Given this list of marker genes Esrrb, Pak1, Aldh1a3, Nr5a2, Nr3c1, Snai2, Trim68, Vps18, Shq1, Dnaja1, Pagr1a, Nkx3-1, Ncor2, Trerf1, Ppargc1b, Cst11, Nr2c1, Lhcgr, Ren1, Appl2, Med1, Zfp536, Ucn3, Heyl, Cyp26a1, Kdm4c, Kank2, Pou4f2, Rnf6, Asxl1, Sfrp1, Nr1d1, Safb2 (scaffold attachment factor B2), Nr1h3, Crkl, Calcoco1, Sst, Ptges3, Safb, Dhrs3, Ghr, Kmt2d, Ddx5, Rwdd1, Lmo3, Snw1, Ddx17, Vps11, Brca1, Foxa1, Rela, Nedd4, Rbfox2, Cnot1, Cnot2, Phb2, Ar, Dab2, Esr1, Nr0b1, Ywhah, Sp1, Rhoa, Actn4, Adipor2, Park7, Per1, Ppard (NCBI Gene Id 69050), Wbp2, Rarg, Ep300, Ncoa1, Greb1l, Fkbp4, Kdm5d, Ncoa2, Ptpn11, Scgb2a2, Clock, Lats2, Foxp1, Cnot3, Pparg, Trp63, a, Trip4, Cry2, Lancl2, Gh, Pml, Akr1c18, Klf2, Nr5a1, Rxrb, Nr3c2, Trim24, Or51e2, Ghsr, Pgr, Nr1h2, Acsl1, Padi2, Abhd2, Ppara (peroxisome proliferator activated receptor alpha), Cnot9, Calr, Crh, Ufsp2, Hdac1, Cry1, Ppp5c, Foxh1, Hmga2, Zbtb7a (zinc finger and BTB domain containing 7a), Rara, Esrrg, Cyp26b1, Mapk1, Sstr1, Prcp, Nr1d2, Crhbp, Carm1, Ncor1, Lbh, Aldh1a2, Adipor1, Tgif1, Sstr3, Tmf1, Pim1, Bdnf, Sstr5, Ddrgk1, Lats1, Pten, Esr2, Trh, Zmiz1 (zinc finger, MIZ-type containing 1), Rxfp1, Gper1, Skp2 (S-phase kinase-associated protein 2, NCBI Gene Id 75034), Gprin3, Ntrk2, Adipoq, Ptf1a, Csnk2b, Klf9, Dnaaf4, Slc27a1 (solute carrier family 27 (fatty acid transporter), member 1), Rxra, Pde3a, Ctbp2, Ubr5, Agrp, Rxfp2, Zdhhc7, Nodal, Ucn2, Uba5, Mn1, Kdm3a, Taf7, Mettl21c, Strn3, Thrb, Prlr, Fshr, Phb1, Rarb, Sstr4, Parp1, Gcgr, Src, Tshr, Ufl1, Appl1, Sstr2, Rxrg, Pias2, Crebrf, Errfi1, Kmt2e, Ostn (osteocrin), Cyp27b1, Cacna1a, Cuzd1, Thra, Srarp, Ghrhr, Ezh2, Prmt2, Tbx1, Isl1, Daxx, Ube3a, Esrra, Bmal1, Arid1a, Gphb5, Smarca4, Akap13, Igf1, Usp26, Tcf21, Rnf14, Jak2, Ufm1, Zfp366, Cyp7b1, Ncoa3, Prl, Vdr (vitamin D (1,25-dihydroxyvitamin D3) receptor), Strap, Sirt1, here is a description of the gene set: Mouse Gene Set: GOBP_HORMONE_MEDIATED_SIGNALING_PATHWAY The series of molecular signals mediated by the detection of a hormone. studied in species Mus musculus